Given this list of marker genes Exosc8 (exosome component 8), Exosc5, Gtpbp1, Exosc4, Exosc10, Exosc2, Exosc9, Exosc7, Exosc6, Dis3l, Carhsp1, Dis3, Exosc3, Exosc1, here is a description of the gene set: Mouse Gene Set: GOCC_CYTOPLASMIC_EXOSOME_RNASE_COMPLEX studied in species Mus musculus A ribonuclease complex that has 3-prime to 5-prime processive hydrolytic exoribonuclease activity producing 5-prime-phosphomonoesters. Participates in a multitude of cellular RNA processing and degradation events preventing nuclear export and/or translation of aberrant RNAs. Restricted to processing linear and circular single-stranded RNAs (ssRNA) only. RNAs with complex secondary structures may have to be unwound or pre-processed by co-factors prior to entering the complex, esp if the 3-prime end is structured.